Given this list of marker genes POSTN, RBX1 (NCBI Gene Id 9978), ANGPT2, CCL7, CFHR1 (complement factor H related 1), UBD, EFEMP1, KRT18 (NCBI Gene Id 3875), PVALB, ESR1 (estrogen receptor 1), HSD11B2, C1S, DYNLL1, KDR, TIE1, TNFSF10 (TNF superfamily member 10), SULT1E1, GALNT1, SAT1, SLC49A4, CD9, GGH (NCBI Gene Id 8836), IFI27, OXTR, MPHOSPH10, FGFBP1, SP3, VCAN, ADD2 (NCBI Gene Id 130935), BMP6, MMP1, DLEU2, NDUFA1, CEACAM1, SDC4, NR4A1, HEMGN, HEXA, THY1, KRT7, COL6A1, BMP4, GJA4, CXCL1, FHL3, SHC3, HCLS1, NNMT, SLC6A8, MRPL19, LMO2, BGN, MGP, PIR, MEST, TFPI2, SGCE, PRR29, SEMA5A, COL6A3, ISL1, VWF (von Willebrand factor), MMP2, ADORA2B, ROR2, GCHFR, MMP10, ELN, PDE4B (phosphodiesterase 4B), BCKDHA, RALA, BDNF, GEM, ADGRE1, RANGAP1, CD34, MALSU1, TRIM23, AQP7, NID2, COL1A2, PGF, ART4, PIM1, FAP, UNG, GSTT1, ANKRD1, FBP1, PRKCI, HTR2B, PNP, FOXO1, CCL2, IL32, here is a description of the gene set: Human Gene Set: WESTON_VEGFA_TARGETS There is evidence that the vasculature of different organs display different functional characteristics in response to cytokines and growth factors. The aim of this study was to use cDNA gene expression microarray to analyse changes in gene expression following stimulation of myometrial microvascular endothelial cells (MMECs) with vascular endothelial growth factor (VEGF). Primary isolates of MMECs were obtained from fresh hysterectomy specimens and purified with magnetic beads. Cells were stimulated with 15 ng/ml VEGF for 3, 6 and 12 h, and two unstimulated experiments served as controls. A total of six arrays was performed over these time-points. A total of genes were identified as up-regulated by VEGF, 19% of which (genes) have previously been reported as up-regulated by VEGF or by angiogenesis. Among the novel genes to be up-regulated by VEGF were brain-derived growth factor, oxytocin receptor and estrogen sulphotransferase. The significance of the genes identified in the physiological and pathological functioning of the myometrial vasculature is discussed. studied in species Homo sapiens Genes up-regulated in MMEC cells (myometrial endothelium) by VEGFA stimulation. from publication Weston GC, Haviv I, Rogers PA (PMID 12200464)